Given this list of marker genes BCOR (BCL6 corepressor), POU4F1, CDC42BPG, ONECUT2, TMPRSS4, OR2C3, MCCC2 (methylcrotonyl-CoA carboxylase subunit 2), MOV10L1, NMRAL2P, FAM86C1P, PCGEM1, TNFAIP2 (NCBI Gene Id 7127), CRYBA2, STPG3-AS1, ROM1 (retinal outer segment membrane protein 1), TEX48, ENSG00000259697, SLC12A1, EFCAB3 (NCBI Gene Id 146779), PLIN5, GABRA1, SSC5D, UTS2B, LUZP4, LINC01141, CCN1, DENND5B, H1-6, WDR83OS, C2CD2, UBE2U, IGLV3-19, ABCD1, LINC01116, DEFB1, DKK1 (dickkopf WNT signaling pathway inhibitor 1), ZNF391, PPM1L, LINC00330, LINC00520, SOX5, FAM131C, USP30-AS1, TCF24, SPIB, MB, SGO2, FGF21, JPH1, ENPP1, CDX4, H2BC14, CYP4F29P, SLC24A3-AS1, SGCE, SLC1A6, GCNT4, EFEMP2, BARX1, DYNLT2, MISFA, FAM149A, PDGFRL, IL1RAPL1, CLDN9, ZFP36, MAP3K11 (mitogen-activated protein kinase kinase kinase 11), ZNF548, CFAP100, WDR72, FOXD3, NHLRC2, FA2H, THAP8, CRACDL, EGFR, DNAJB8, AREG, APC2, DPY19L1P1, ADAMTSL4, RAB30-DT, FCRL4, TEKT1, DTX4, FRY-AS1, PRKN, RIBC2, GAB3, LILRP2, EPB41L3, KRT3, ITPKA, LINC00698, GASK1B, CELA1, PHLDB1, GABRA6, KLK6, PHACTR2-AS1, SPINK7, SORBS3, CCL24, S1PR3, LAG3, TNKS1BP1, KCNJ14, HOXA7, EYS, C16orf82, AHI1-DT, STT3A, GYG2, ZNF334, STAR, FOXB1, GAS6, PCDH17, UBXN11, NTRK3, C19orf18, EFS, IGHD, PGA3, MRM1, STXBP5-AS1, HPGDS, C3orf49, CXCL6, HTR3A, PRR19 (NCBI Gene Id 284338), NOXO1, CPED1, ZNF778, FBXO36, LY6G6E, ASPDH, NETO1, LRRC63, IMPG2, DUSP13B, TREML1, TAFA2, LTB4R2, PRRX2, SPIRE2, RASL10B, C22orf31, LINC01366, FAM184A (NCBI Gene Id 79632, family with sequence similarity 184 member A), PLA2G10, KAZN, DNMT3B, WIZ, CCDC181, S100A14, TBX19, FAM167A-AS1, ST8SIA2, GLMN, ST18 (ST18 C2H2C-type zinc finger transcription factor), FAM83G, OR7E87P, HSD17B6, ABCB9, SPATA31C2, PGLYRP2 (peptidoglycan recognition protein 2), FEZ1, SLCO4C1, PPP2R2B, LINC00485, SLC7A9, ZNF521, CRYBB1, OR5V1, HOXC11 (homeobox C11), SAP30L-AS1, PLEKHA8, USP2, FXYD1, ZNF48, HYAL1, C8orf44, TRIM6, FABP3, IGFBP5, here is a description of the gene set: Human Gene Set: GSE17974_IL4_AND_ANTI_IL12_VS_UNTREATED_0.5H_ACT_CD4_TCELL_DN The aim of this dataset was to study in detail the transcription kinetics initiated by cytokine IL-4 in early differentiation of Th2 cells. Genes down-regulated in comparison of CD4 T cells treated with IL4 and anti-IL12 at 0.5 h versus the untreated cells at 0.5 h. from publication Elo LL, Järvenpää H, Tuomela S, Raghav S, Ahlfors H, Laurila K, Gupta B, Lund RJ, Tahvanainen J, Hawkins RD, Oresic M, Lähdesmäki H, Rasool O, Rao KV, Aittokallio T, Lahesmaa R (PMID 20620947) species: Homo sapiens